The following is a description of a gene set: Genes up-regulated in comparison of CD8 T cells at 0 h versus those at 48 h after stimulation with IL12. Differentiation of naive CD8 T cells into cytotoxic effector cells requires three distinct signals- antigen (signal 1), costimulation -B7-1 (signal 2) and cytokine, either interleukin-12 or interferon-a/b (signal 3). Interaction of naive CD8 T cells with antigen and B7-1 programs cell division and proliferation whereas the presence of cytokines- IL-12 or IFNa/b promote survival, differentiation and memory establishment. In the absence of signal 3, the cells interacting with antigen/B7-1 undergo tolerance induction. The objective of this study was to elucidate the mechanisms how the provision of signal 3 promotes differentiation and averts tolerance induction in CD8 T cells. Trichostatin A is a pharmacological agent that inhibits histone deacetylase activity, hence regulating chromatin structure and gene expression and differentiation in many cell types. Gene signature profiles of IL-12, IFNa/b and trichostatin A stimulated cells were compared to elucidate the molecular mechanisms of gene regulation. Oligonucleotide microarray analysis is carried out to determine the extent and molecular nature of the CD8 T cell differentiation program induced by IL-12 or IFNa/b in concert with antigen and B7-1 signal. Human Gene Set: GSE15930_NAIVE_VS_48H_IN_VITRO_STIM_IL12_CD8_TCELL_UP species: Homo sapiens from publication Agarwal P, Raghavan A, Nandiwada SL, Curtsinger JM, Bohjanen PR, Mueller DL, Mescher MF (PMID 19592655), and this is the list of marker genes: RCVRN, SPATA6, P2RY2, ADGRL1, HAO2, ZBTB20, RBM4B, GJA3, TCF7 (transcription factor 7), SDC3, CHKA, CLTB, TNNC2, NRTN, GCG, GCSAM, EEF1A2, MROH1, RETREG2, PCDHA10, NMUR1, TRAPPC14, EFNB2, BRAP, ZNF292, PRKCD, CLPS, PI4K2A (phosphatidylinositol 4-kinase type 2 alpha), SIAH1, CCNDBP1, SLC39A4, STX2, RAPGEF4 (NCBI Gene Id 11069), ADORA1, RAB33B, SOX4, CD14, SLCO3A1, FRMD8, ALAS2, RECK, VPS51, HLA-DOA (major histocompatibility complex, class II, DO alpha), OSBPL5, PIP5K1A, NTRK3, ABCD1, RFXANK, TRIM13, DENND2B, HR, CACNA1C, GUCY2D, PBX2, MAP4K3, DPYSL3, IFIH1, SCMH1, DNAJB4, LIPA, CANT1, TCN2, PSAP, F2RL1, KLF2, HIPK2, SNX17, NREP (NCBI Gene Id 9315), RAB5B, PHC1, HINT2, LDB3, ULK2, ZRANB1, DIAPH1, RFX2 (NCBI Gene Id 5990), STAT5A, SLC7A11, NR1D2, RPL12, RGS3, COLQ (collagen like tail subunit of asymmetric acetylcholinesterase), IRF9, RPL32 (NCBI Gene Id 6161), IL16, DVL1, BLOC1S1, GGPS1, ST3GAL1, MOV10, SUMO2P7, KIAA0319L, PHRF1, SEC11C, MFGE8, ITGB3, IKZF2, KRT5, GALNT10, CD79B, COL6A2, SLC27A1, ADRB2, USP2, PEA15, IP6K1, SPINK4, FGF7, ADCY6, TBR1, RPS27, IL6R, FRAT1, TLE4, MAL, ABCG1, ING4, USP25, GSTM1, GZMA, METTL17, KRT1, MAP4, BMP6, ACKR3, GNA11, BTRC, DAO, CFH, BPIFA2, MAPK8IP3, SH3GL1, MYORG, CD1D, GRIK1, HOXA11, INSM1, STK24, ERCC2, MAP1LC3A, FLT3LG, RERE, IFI27, ELF4, RAE1, CWC22, RETN, MSL2, IL27RA (interleukin 27 receptor subunit alpha), PDE4B (phosphodiesterase 4B), LAPTM4B, GRINA, CAMK2B, ZYG11B, UROS, BRWD3, TPT1, FBXW4, ATP9A, CUX1, TANC1, ARID3B, P3H3, METTL8, BSDC1, TBC1D20, QSOX1, EPHB2, LYST, DTX1, RASAL1, KCNQ1, KLC4, NEDD4L, GABBR1, LMX1B, GP1BB (glycoprotein Ib platelet subunit beta), SCAF8, INPP5K, ABCC5, FLG (NCBI Gene Id 83406), PDE1B, LTBP1, VIPR1, CMPK2, RPS15A, SLC22A1, SLC4A2 (NCBI Gene Id 96677), CASQ1, ABCA2, PHF1, ICMT, PLEKHA5, AP1B1, FOSL2 (NCBI Gene Id 79579), KLHL21, PAK4, MBTD1, B4GALT1